The following is a description of a gene set: Human Gene Set: HP_LOW_SET_NIPPLES species: Homo sapiens Low-set nipples Placement of the nipples at a lower than normal location., and this is the list of marker genes: MPLKIP, GTF2H5, KAT6A (NCBI Gene Id 7994), RNF113A, TARS1, GTF2E2, H3-3A, ERCC2, PIGL, ERCC3, CARS1, AARS1